The following is a description of a gene set: species: Homo sapiens Human Gene Set: MIR19B_1_5P_MIR19B_2_5P Genes predicted to be targets of miRBase v22 microRNA hsa-miR-19b-1-5p, hsa-miR-19b-2-5p in miRDB v6.0 with MirTarget v4 prediction scores > 80 (high confidence targets). from publication Chen Y, Wang X (PMID 31504780), and this is the list of marker genes: AGFG1, ZNF28, TNPO1 (NCBI Gene Id 3842), CREB3L1, ANKRD36B, MPP7 (MAGUK p55 scaffold protein 7), ZNF765, ACACB, BCL11B, PMPCB, ABRAXAS1, TUB, ZFAND1, ZMYM5, SLC44A1, ALDH1A2, SLITRK4, HNRNPR, CP, TRIM7, PLCB4, CREBRF, MOSMO, RUNX2, CENPF, XIAP, ARPC5, SMCO3, MAN1A2, KLHL15, IL23R, SLC39A8, GSTA2, FAXC, SGIP1, TMEM192, GABRB2, PTPRJ, NIPBL, POLQ, KMT2E, ABCB10, SEL1L, CAMTA1, WWP1, ZNF813, NR2E1, DCLK1, TMEFF2, FYTTD1, CFL2, NR4A3, RLIM, STXBP5, TNS4, ZNF888, IFI35 (interferon induced protein 35), RORA, MSRB3, ZNF578, IKZF5, PALLD, FARP1, ZNF439, KCND2, EIF2S1, BRINP1, PHF20, ANO3, ZNF345 (zinc finger protein 345), ANKS1B, GNAQ, ZNF761, ITPRIPL2, NTS, PHYHIPL, RPP14, ZNF611, EIF4G2, ZNF468, TPD52L3, ELOVL6, EXOSC8, PPARGC1A, PDE1C, SLC35F1, ZNF808, MKX, PBX1, CRACDL, FBXO8, ANKRD52, AGPAT3, NRXN1, PUM2, CAB39, PRDM13, TET2, CREB1, ACVR1C, ZNF845, HIPK1, GNA13, PAN2, TRPS1, FKBP5, PCDHGA7, CCN2, GPATCH11, COG5, C1QTNF9, CHL1, PSMC1, FRMD4A, LRRTM3, SEZ6L, ESCO2, LIN7C, HOXA2, XKR6, EDNRB, HSPB8, PGR, ZNF600, ELAVL4, GATM, IL17A, RNF169, FLRT3, CENPN, FGF13, BBX, IFT70A, MEX3D, SLC6A8, SPRED2, PLXDC2, UBE2R2, TENM1, ZNF860, ZBTB2, GRIK2, UBR7, CGGBP1, THAP11, HIVEP2, CSRNP2, ZNF816, UBE2D4, SETD6, NEK7, GABPA, PLEKHO2, AGO1, PNPLA4, EDN1, PURB, PTCD2, MS4A4A, RBMS3, LATS1, UNC5C, EMP1, FSCN3, TMEM255A, CREBL2, FHL5, LIN28B, TMEM131, USP50, WDSUB1, DERL1, AJAP1, FAM120A, CNOT7